Given this list of marker genes SERPINB3, CR1, PSENEN, MBP, SEMG1, PRELID1, SEMG2, VSIR, here is a description of the gene set: species: Homo sapiens Human Gene Set: GOBP_POSITIVE_REGULATION_OF_ENDOPEPTIDASE_ACTIVITY Any process that increases the frequency, rate or extent of endopeptidase activity, the endohydrolysis of peptide bonds within proteins.